Given this list of marker genes CLPB, HSPA1A, HSPA1B (NCBI Gene Id 3304), HSPA8, NSF, VPS4A, here is a description of the gene set: species: Homo sapiens Human Gene Set: GOMF_ATP_DEPENDENT_PROTEIN_DISAGGREGASE_ACTIVITY An ATP-dependent molecular chaperone activity that mediates the solubilization of ordered protein aggregates.